The following is a description of a gene set: Human Gene Set: PID_HES_HEY_PATHWAY Notch-mediated HES/HEY network from publication Schaefer CF, Anthony K, Krupa S, Buchoff J, Day M, Hannay T, Buetow KH (PMID 18832364) species: Homo sapiens, and this is the list of marker genes: RBPJ, GAA, TCF3, CAMK2D, BGLAP, E2F1, CTBP1, CD4, NCOR1, PARP1, EP300, PTF1A, RUNX2, HES6, RBBP8, HDAC1, STAT3, RCAN1, YY1, KDR, HEY2, HIF1A, NCOR2, JAK2, TWIST1, HEY1, HES1, RB1, NCOA1, GATA4, AR, GATA6, GATA1, MYOD1, MAML1, CREBBP, GHR (growth hormone receptor), CDKN1B, NEUROG3, KDM1A, TLE1, MAML2, ID1, SPEN, ARNT, NOTCH1, ASCL1, MYB